Given this list of marker genes Scn2b (NCBI Gene Id 72821), Akap13 (A kinase anchor protein 13), Tmem151a, Pik3r1, Cst6, Slc2a12, Gfra2, Grm1, Fntb (NCBI Gene Id 70263), Nectin1, Gabra1, Galnt16, Arpin, Ccni, Mtcl2, Usp3, Emd, Zfp445, Plekhh1, Man1b1, Slc35f6, Srd5a1 (NCBI Gene Id 78925), Amotl1, Smug1, Notch2, Slc16a2, Cobl, Plec, Zfhx4, Natd1, Sqor, Tm9sf2, Stk40, Tarbp2, Cntf, Ssh2, Tspan7, Mau2, Kif21b, Atad3a, Itgal, Colec12, Cd164, Secisbp2l, Ctnnd1, Klb, Rbm15 (RNA binding motif protein 15), Hgf, Kcnn3, Pgm3, Azi2, Pskh1, Agtrap, Dnajb2, Ppfia2, Syncrip, Hdac11, Spry1, Kif5b, Tob2, Cep15, Trib2, Klhl18, Mmp14, D430041D05Rik, Krtap4-21, Usf3, Ergic1, Tsga10, Dync1li1, Dnaaf9, Pax7, Slc27a4, Hpcal1, Apod, Krtap4-13, Syt2, Cyp2b13, Myot, Tmem47, Smg1, Hdhd2, Vwc2l, Syt15, G6pc1, Necap2, Dpys, Ttbk1, Rap2a, Ctbp2, Pcdhb13, Chrd, Krtap4-20, Nedd4l, Ehhadh, Cyp2b23, Rnf144b, Tagap, Zbed4, Plppr1, Naga, Myo18a, Slc10a2, Slc5a8, Ccdc127, Lpar2, Fam135a, Kpna3 (NCBI Gene Id 16648), Gpr50, Zc3h11a, Mlec, Tcte2, Cplx2, H13, Syne3, Epha4, A430033K04Rik, Slc27a1, Rbm4b, Ndufa4l2, Kif24, Sdhd, Zc2hc1a, Trhr, Chchd6, Shank1, Nr1h2, Pdcd7, Ttll5, Cldn19, Vwa3a, Ppp3ca, Jazf1, Daglb, Pde2a, Orc6, Bckdk, Tnk2, Zfp113, Nanos1, Tbc1d16 (TBC1 domain family, member 16), Aff4, Fmr1, Crbn, Orc1, Slc6a11 (solute carrier family 6 (neurotransmitter transporter, GABA), member 11), Dus3l, Mmp25 (matrix metallopeptidase 25), Limch1, Wnt9a, Emc10, Gpatch11, Tcl1b5, Mdga2, Sh2b3, Tbc1d4 (TBC1 domain family, member 4), Zfp1006, Ddb1, Sstr5, Itgb3 (NCBI Gene Id 268495), Scn3a, Sbno1, Nhsl3, Cyp46a1, Pitrm1, Rtl6, Zfp598, Pramel21, Smpd3, Nynrin, Cbln1, Nemp1, Tesk2, Capn5, Csmd1, Il1b, Pbx3, Zzef1, Tmem81, Cstf3, Mdga1, Slc24a2, Celsr2, Ctdspl, Ccdc96, Slc39a2, here is a description of the gene set: Genes predicted to be targets of miRBase v22 microRNA mmu_miR_7064_5p in miRDB v6.0 with MirTarget v4 prediction scores > 80 (high confidence targets). from publication Chen Y, Wang X (PMID 31504780) studied in species Mus musculus Mouse Gene Set: MIR_7064_5P